Given this list of marker genes Nqo1, Kcna5, Tnfaip3, Pdgfd, Mb, Rela, Crk, Ngb, Rps3, Map1lc3a, Becn1, Gja3 (gap junction protein, alpha 3), Nfe2l2, Ankzf1 (ankyrin repeat and zinc finger domain containing 1), Gata5, Txnip, Lck (lymphocyte protein tyrosine kinase), Il6, Abcc9, Prdx3, Casp6, Ube3a, Prkaa1, Ppp1r15b, Cryaa, Cryab, Ezh2, Gpx1, Trpm2, Ppp2cb, Bnip3, Lig1, Cyp1b1, Pcgf2, Cdk1, Src, Sod2, Col1a1, Zfp580, Cfl1, Sirt1, Hsf1, Aifm1, Oser1, Axl, Cat (catalase), Anxa1, Rnf146, Ednra, Setx, Abl1, Foxo1, Trpa1, Capn2, Areg, Ripk1, Kpna4, Mapk8, Zfp277, Fabp1, Map3k5, Prkcd, Ern1, Ect2, Mapk7, Net1, Stat6, Trpc6, Fkbp1b, Capn1, Bak1, Sod1, Ripk3, Pdgfrb, Slc4a1, Sirpa, Edn1, Adam9, Hmox1, Ppif, Sdc1, Akr1b1, Lcn2, Ptk2b, Txn1, Klf2, Sirt6, Cyp11a1, Casp3, Mmp2, Fchsd1, Nr4a3, Fosl1, Ppef2, Park7, Kdm6b, Fxn, mt-Nd5, Bcl2, Aqp1, Cdkn2a, Smpd3, Plekha1, Mdm2, Mapk13, Pld2, Cbx8 (chromobox 8), Apex1, Hdac6, Hspa8, Rhob, Top2b, Hdac2, Klf4, Fyn, Pcna, mt-Nd6, Sphk1, Il18rap, Star, here is a description of the gene set: studied in species Mus musculus Any process that results in a change in state or activity of a cell or an organism (in terms of movement, secretion, enzyme production, gene expression, etc.) as a result of a hydrogen peroxide (H2O2) stimulus. Mouse Gene Set: GOBP_RESPONSE_TO_HYDROGEN_PEROXIDE